Given this list of marker genes CNTNAP2, MAG, NCMAP, SPTBN4, CLDN5, EPB41L3, ERMN, KCNA1, SIRT2, CNTNAP1, here is a description of the gene set: species: Homo sapiens An axon part that is located adjacent to the nodes of Ranvier and surrounded by lateral loop portions of myelin sheath. Human Gene Set: GOCC_PARANODE_REGION_OF_AXON